The following is a description of a gene set: species: Mus musculus Genes predicted to be targets of miRBase v22 microRNA mmu_miR_1971 in miRDB v6.0 with MirTarget v4 prediction scores > 80 (high confidence targets). from publication Chen Y, Wang X (PMID 31504780) Mouse Gene Set: MIR_1971, and this is the list of marker genes: Ncbp2, Rap1b, Plcb1, Aldh1a3, Zmpste24, Crip1, Abracl, Slc25a53, Tead1, Ing3, Plp2, Galnt1, Nipa1, Sox17, Phc3, B3galt1, Sp1, Zbtb33, Igf2bp3, Spire1, Cdc37l1, Slf2, Fundc2, Tmem106b, Abhd2 (abhydrolase domain containing 2), Vipr2 (NCBI Gene Id 22355), Tshz3, Mms19, Ptprk, Ago4, Calu, Tbc1d8, Mmd, Myo1e, Nxpe2, Snx18, Glb1l3, Ago3, Ncapg2, Vapa, Lrrc41, Zfp493, Degs2, Ppargc1a, Dag1, Rimklb, Sox18, Nlrp10, Dpy19l1, Celf6, Uqcrq, Pard3, Lrp11, Oxct1, Mis18a, Zfp850, Tle1, Fzd4, Rab5b, Rit2, Tra2b, Qser1, Lrrc7, Hspa9, Klhl24, Mlf2, Hdhd2, Zfp52, Carmil1, Pde2a, Snx30, Palld, Rtkn2, Zfp955a, Smg7, Wnk3, Tfr2, L2hgdh, Rwdd3, Taf1, Mysm1, Lactb, Fgfbp3, Wtap, Nkiras1, Spout1, Psg25, Ppfia2, Ppp1r11, Idua, Reep1 (NCBI Gene Id 97333), Klhl23, Nfatc2, Zfp937, Gprc5b, Gatad2a, Dipk2a, Mettl2, Cdc5l, Gid4, Zmynd11, Nrip3, Mre11a, B3galt2, Rere, Igf2r, Rhbdd2, B3galnt2, Trem5, Ccdc88a, Sestd1, Gata3, Svip, Orc2, Cxcl3, Pak5, Polr1b, Usp37, Rcn2, Rbfox2, Rab3gap2, Mettl21e, Sos1, Usp15, Ppp1r3d, 2310022B05Rik, Gm9758, Cd9, Thsd1, Gm17019, Ddx3x, Mier3, Gata2, Klhl42, Pappa, Fam177a2 (NCBI Gene Id 100101807), Atp1b2, Ssr1, Ntsr1, Osbpl8, Tra2a, Phtf2, Brd4, Zfp62 (NCBI Gene Id 22720), Mapk4, Gja6, Tsen54, Ncam1, Papola, Kif26a, Slc34a2, Seh1l, Padi1, Lbr, Nup50, Eif4a2, Tmem132d, Elavl1, Bex3, Usp45, Uba2, Rora, Thnsl2, Stom, Mical2 (NCBI Gene Id 70877), Tnrc6b, Itsn2, Accs, Gm11545, P3h4, Rfx3, Vcl, Ikzf5, Dennd4a, Bhlhe40, Slc25a28, Plekhh1, Ccsap, Alg9, Sap18b, Nrn1, Jazf1, Becn1, Gabpb2, Zfx, Ythdf3, Fam177a, Zfp386, Retnla, Etv3, Hectd2, Ino80d, Cby1, Rnf6, Maoa (NCBI Gene Id 68831), Tulp4 (NCBI Gene Id 78646), Peg3